The following is a description of a gene set: species: Homo sapiens S100A12-hi cla. mono. Human Gene Set: HE_LIM_SUN_FETAL_LUNG_C2_S100A12_HI_CLASSICAL_MONOCYTE from publication He P, Lim K, Sun D, Pett JP, Jeng Q, Polanski K, Dong Z, Bolt L, Richardson L, Mamanova L, Dabrowska M, Wilbrey-Clark A, Madissoon E, Tuong ZK, Dann E, Suo C, Goh I, Yoshida M, Nikolić MZ, Janes SM, He X, Barker RA, Teichmann SA, Marioni JC, Meyer KB, Rawlins EL (PMID 36493756), and this is the list of marker genes: ASGR2, RAB27A, CLEC4E, S100P, THBS1, CDA, VSTM1, G0S2, SLC11A1, MCEMP1, HK3, DYSF, BST1, NFE2, PELATON, VCAN, STEAP4, MGST1, MEGF9, VNN2, LILRA5, S100A12 (S100 calcium binding protein A12), ADM, KCNE1, LRRK2, ASGR1, OLIG1, PADI4, S100A8, RBP7, MTMR11, TREM1, RNASE2, CKAP4, LTB4R, FCN1